Given this list of marker genes Ppp1cb (NCBI Gene Id 231111), Ppp1r3c, Gfpt1, Ins2, Insr, Ppp1r3g, Igf2, Akt2, Khk, Akt1, Ppp1r3b, Ppp1r3d, Phka1, Gcgr, Ppp1r3e, Phkg2, 1810024B03Rik, Irs1, Mtor, Rubcnl, Ppp1r3f, Adra1b, Hmgb1, Epm2aip1, Pask, Phlda2 (NCBI Gene Id 22113), Sorbs1, Ins1, Enpp1, Igf1 (NCBI Gene Id 320499), Phkg1, Inpp5k, Pomc, Pth, Ppp1r3a, Adcy10, Gck, Prkag3, Irs2, Gsk3b, Grb10, C1qtnf2, Esrrb, Phkb, Dyrk2, Ppp1ca, here is a description of the gene set: species: Mus musculus Mouse Gene Set: GOBP_REGULATION_OF_GLYCOGEN_METABOLIC_PROCESS Any process that modulates the frequency, rate or extent of the chemical reactions and pathways involving glycogen.